The following is a description of a gene set: Each fraction of mouse hematopoietic cells was purified by cell sorting from bone marrow of 8-week-old C57BL/6 mice, and its gene expression was analyzed. Human Gene Set: GSE27786_LSK_VS_LIN_NEG_CELL_UP Genes up-regulated in comparison of LSK versus lineage negative cells. studied in species Homo sapiens from publication Konuma T, Nakamura S, Miyagi S, Negishi M, Chiba T, Oguro H, Yuan J, Mochizuki-Kashio M, Ichikawa H, Miyoshi H, Vidal M, Iwama A (PMID 21540074), and this is the list of marker genes: RAMP1, FOXO3, CTDSP2 (CTD small phosphatase 2), GLTP, IFIT1B, DPF2, DAG1 (dystroglycan 1), GABRR1, ZNF799 (zinc finger protein 799), CEP57L1, MFSD3, NFKBIE, NUDT16, ANTXR2, GLB1, RAB11A, NIPAL3, NOP53, GAS2L3, TES, DPP4, ZBTB20, GPATCH2, SKIC3, SNRK, COQ8A, ATXN7, SLTM (NCBI Gene Id 79811), SMAD1, SLC2A9, CUL9, EIF4E3, LMO2, HAGHL, BRI3, PAFAH1B3, LARGE1, TAP2, ADAM22, SEC31A, HMGN3, ATXN10, AFTPH, MSI2, CD72, TAF5L, LAPTM4B, SAP30L, HOXA9, TANC2, ANAPC10, ZC3HAV1L, TNNI3, CPQ, AFP, ABHD4, TBXAS1, TNFRSF1A, TSPAN3, SH3BP5, C19orf48P (NCBI Gene Id 84798), VAPB, COL4A1 (NCBI Gene Id 1282), KCND1, NRAP, FOXRED2, AKT1, CLIP1, FOXD2, ZDHHC8, OPA3, CCND1, SPNS3, BSCL2 (NCBI Gene Id 84753), GMPPA, ZNF292, CSNK1E, NRBP1, PLEKHA8 (NCBI Gene Id 84725), SLC44A2, PTGER3, PAF1, TGIF2, FDXR, GPRASP2, PGGHG, NFAT5, NBEAL2, RNF217, POLL, MFNG, MFSD13A, PIK3AP1, RPS6KA6, ERAP1, USP54, MEF2D, B9D2, KCTD12, LDAF1, SCARF1, KCNJ14, CSGALNACT1, ERGIC2, SLC25A20, C11orf68, BCKDHA, LRRC66, ELOVL6, RAB27A, TGFB3, CAMSAP3, CTXN1, TMUB2, RPS25, HSD17B11, NME2 (NME/NM23 nucleoside diphosphate kinase 2), H1-0, KHDRBS3, RAB5A, AKAP8L, ALDOC, RTL8C (NCBI Gene Id 8933), PLCB2, TIRAP, TRIQK, TNFRSF13B, MBTPS2, TRIP6, FAM221A, FLOT1, RPL38, OAS3, FOXJ3, INTS1, CRTAP, EVA1B, CRY1, ABHD17B, RCBTB1, SDR39U1, HGF, HOOK2, PARP14, CAPZA2, PDK4, TSPAN14, CAPNS1, RSAD2, VSIG10 (NCBI Gene Id 54621), DGKG, FAM43A, VPS39, POLR1H, FAM98C, PWWP3B, TF, LSM14B, SGCE, CD244, MAF1, BOD1, GSTM4, TMEM42, STING1, ZNF879, CD27, KANSL3, DBNL, ZCCHC2, SORBS3, MVB12A, HDAC6, RIOX2, CIC (capicua transcriptional repressor), RASA4, GIMAP6, KIF3C, ZFAND5, LENG1, RNF4 (ring finger protein 4), CMTM7, BTBD8, C6orf132, ELOVL5, CBFA2T2, ODF2L, MBNL2, ELMO2, TTLL4, HS1BP3, CISH, MPL, SLC22A3, TDRD7, HES6, ARFIP1, AGPAT2, KMT5B, MFGE8